The following is a description of a gene set: Enables the transfer of bile acid from one side of a membrane to the other. Bile acids are any of a group of steroid carboxylic acids occurring in bile, where they are present as the sodium salts of their amides with glycine or taurine. Mouse Gene Set: GOMF_BILE_ACID_TRANSMEMBRANE_TRANSPORTER_ACTIVITY species: Mus musculus, and this is the list of marker genes: Abcb11, Slc10a2, Slco1a5, Slc10a4-ps, Slc10a1, Abcc4, Slc10a3, Slco1a4, Slc51a, Abcc3, Slco1c1, Slco2b1, Slco1a1, Slco1b2, Slc10a4, Ceacam1, Slc51b, Slc10a5 (solute carrier family 10 (sodium/bile acid cotransporter family), member 5), Slco1a8, Slco1a7, Ceacam2, Slc10a6, Slco1a6, Slc10a7